The following is a description of a gene set: An abnormality of the viscera of the abdomen. Human Gene Set: HP_ABNORMALITY_OF_THE_ABDOMINAL_ORGANS Abnormality of the abdominal organs species: Homo sapiens, and this is the list of marker genes: FTH1, CCDC40, RFT1, HBA2, GBA1, KIF23, GYPC, CEP164, DNAAF1, CFAP74, DIS3L2, DNAAF6, ALDOB, PNP, KRIT1, HGSNAT, STOX1 (storkhead box 1), THPO, AGA, CD3E, RFX5, SLC16A1, SCO1, AGGF1, CBL (NCBI Gene Id 867), NUP133, CCDC28B, EOGT, ATP11C, PPOX, ATP6AP1, IL12A, NPHP3, NKX2-1, IFIH1, TRPV6, VPS4A (NCBI Gene Id 27183), MITF, CSPP1, PPP2R3C, DNAI2, USB1, ERCC1, RERE, FANCF, PMS2, UFD1, TWNK, ACVRL1 (NCBI Gene Id 94), MOGS, SLC44A1, MEG3, CYP2R1, PHKG2, RRM2B, ADAR, SKIC3 (SKI3 subunit of superkiller complex), PKD1L1, ATP6AP2, SRP54 (NCBI Gene Id 6729), SUMF1, SLC10A1, SDHC, RASGRP1, HADHB, SLC39A7, RFC2, BCL2, DUOX2, GLB1, SMAD2, MMP21, GDF2, BICC1, NME5, SLC26A9, ARPC5, TPI1, CD55, TCTN3, TMEM107, TCF3 (NCBI Gene Id 6929), MT-ND1, PTPN3, GNMT, CDKN2B, POU2AF1, BBS1, SEC63, PUS7, GAPVD1, ABCC8, CFAP300 (NCBI Gene Id 85016), FECH, CEACAM6, GNPTAB, NAB2, PEX19, FANCL, DVL1, GTF2IRD1, MUC5B, TELO2, FAT4, TNFRSF1A, MEFV, ITPR1, CLCA4, SPIB, INS, PSMB8, GCK, AKR1D1, FLNB, SPRTN (NCBI Gene Id 83932), MYRF, FUCA1, CEP83, DLD, FH (NCBI Gene Id 83748), PRKCD, LPL, MNX1, NUP37, MTX2, NTHL1, DNAAF11, PCK1, STX5, CPA1, RHCE, PIK3CG, GPR101, CD79B, INPP5E, PTPRO, XPR1, IGHM, IRF4, FGG, MYCN, PCSK9, EPOR, RAB27A, KCNN4, HBA1, PAX2, CFB, RINT1, CFAP53, MCM4, TFAM, HNF1A, MCM10, CPT2, PEX14, ADAMTS3, SCO2, SEC24C, VPS11, SLC25A4, SLC26A4 (solute carrier family 26 member 4), ACAD9, CHEK2, SDHB (succinate dehydrogenase complex iron sulfur subunit B), TMEM270, TSHR, RAB23, PRSS1, MT-TK, BAZ1B, MVK, SLC6A14, DEF6, GUSB, HLA-DRB1, BBS4, POT1, HESX1, MRPL3, MAGT1, NOTCH1, EWSR1, DYNC2I1, BBIP1, PEX11B, KMT2D, PIGM, FLNC, LARS1, WNT7B, UQCRFS1, AGPAT2, LYZ, MT-TH, CENPF, DLK1, TUFM, LUZP1, DNAH1, FLT1, PCCB, TRIM37, NPC1, LIG4, FOS, GP1BB, SCYL1, PIBF1, RFX6, PDGFB, EPCAM, ABCD3, STAT1, OTC, GNS, TNFRSF11A, NSD1, TBL2, IGKC, PTF1A, SLC5A5, ACD, IL2RB, ABL1, MMACHC, PEX6, HEXB, MPIG6B, GATA2, RFXANK, RAD50, JAG1, MT-ATP6, HSPG2, NCF1, MTR (NCBI Gene Id 4548), IFNG, TULP3, VPS13A, UCP2, IRAK4, SYK, CPT1A, MYBPC3, IFNGR1, SLC39A4, CARD11, LRRC8A, SH2B3, PRKCZ, CD2AP, CAV1, FANCG, ATP5MK, IFT74, DNAAF2, TRAC, NDUFAF4, ATP7A, UROS, TNFRSF9, NAF1, CCDC47, IL21R, ABCC6, COX5A, KMT2B, SCNN1A (NCBI Gene Id 6337), IL7R, WDPCP, LMNA, INSR, ITK, NAE1, TPO, SAMHD1, CD96 (CD96 molecule), FMO3, LIPE, LZTFL1, WDR35, LDLR, NCKAP1L, PLEC, LHX3, DCDC2, GALM, COX14 (cytochrome c oxidase assembly factor COX14), ELANE, HMGCL, MT-TS2, PIK3R1, SMARCAL1, MT-CO3, CD70, KIF3B, SCNN1B, KCNQ1, PPARG, ARX, CFAP221, ADA2, DYNC2H1, OTUD5, TP53, MIF, DDOST, TRAF3IP1, ODAD4, LAT, ATP7B, IER3IP1, RTL1, TINF2, ACBD6, BTNL2, ALAS2, NBEAL2, COG1, SLC25A1, IFT172, SH2D1A, AP3B1, RHD (NCBI Gene Id 6007), GUCY2D, IL36RN, APOC2, AKT1, HMOX1, FTL, TALDO1 (transaldolase 1), HMBS, SCAPER, NBAS, ANLN, NME8, DHCR24, BARD1, FANCM, STXBP2, HOXD13, IKBKG, VPS45, G6PC3, FOXJ1 (forkhead box J1), ADAMTS13, ZFTA, PRKCSH, MECP2, CSF3R, NPHS2, IFT140, NDUFS4, C4A, IL17F, ACTN4, CA2, LRBA, GTF2IRD2, RMND1, POLE, CDKN1C, TWIST1, SMAD4, ITCH, SERPINA1, UBR1, BCR, NSD2, DNASE2, SMARCE1, SOCS1, GANAB, CD19, CLIP2, PIK3CA, STK36, ALG9, ATM, SKIC2, SLC34A2, HBB, PEX12, POU6F2, RNASEH2C, HADH, UBE4B, DNAJB13, NUP205, AIP, AP1S1, PALLD, INPPL1, CLPB, ARSA, SPAG1, KRAS, MCTS1, TTC8, LSM11, CTRC, ATRX, LYRM4, RAG1, CCND1 (NCBI Gene Id 893), BPGM, IRF5, ALDOA, TRMT5, SLC19A1, TNFRSF13C, BLK, CD27, GCGR, PTEN, HSD17B4, MAPK8IP3, RAD51C, TMEM70, RAD51, GPC4, TLR8, TFE3, SMPD1, CAVIN1, BCL11A, IRF2BP2, FOXF1, CFAP410, ALG1, MT-TQ, SAA1, MT-ND3, ABCG5, HSD3B7, RPSA, SPEF2, HCK, RMRP, GNB2, TIMMDC1, SLC51B, TCF4, ARHGDIA, ABCC2, AXIN1, PKD2, ABCB11, NDUFS8, B4GALT1, GPIHBP1, AFF4, SIK3, TRIP13, VPS37D, ATP5F1D, PAX8, SFTPA2, PGM1, RSPH1, AIRE, ANKS6, UBAC2, DNAH5, KDM6A, MT-ND4, CFC1, BRAF, STX11, PNPLA2, CCNO, CASK, FOCAD, CD79A, KYNU (kynureninase), FANCI, SPIN4, NCF4, SPOP, LTBP3, SAR1B, PRSS2, PCCA, KRT18, DNAAF5, NODAL, NUP107, SLC7A7, USP9X, APPL1, CDK4, CTCF, APOB, NFKBIA, PMM2 (NCBI Gene Id 5373), TERF2IP, SLC20A2, TF, ETFB, PRIM1, CPLX1, TPP2, CYP7A1, PYGL, DNAJC19, RECQL4, SCN4A, CFAP298 (NCBI Gene Id 89757), PDGFRL, SMARCD1, NPHS1, BAP1, NDUFA6, CASR, TRHR (thyrotropin releasing hormone receptor), ARVCF, PTPN2, RSPH4A, FANCD2, FDX2, MRE11, CTNNB1, FCGR2A, CDIN1, B9D2, PEPD, MT-TL1, EXTL3, FAM111A, CDKN2C, CEL, ORAI1, VPS33B, SCARB2 (NCBI Gene Id 950), FASLG, FYB1 (NCBI Gene Id 55458), NDUFS6, SHARPIN (SHANK associated RH domain interactor), AHDC1, CCDC39, ADAMTSL2, TRAPPC11, RPGR, SKI, ERCC8, ACOX1, HTRA2, BBS2, MRAS, ZNF699, FAM111B, KLF11, NDUFS7, NDUFV1, IL1RN (interleukin 1 receptor antagonist), DNAH11, TNPO3, IFT80, MT-TN, CDC73, DMPK, NR1H4, ZEB2, ARL6, PCSK1, ARID2, YME1L1, PIK3CD, POU1F1, ARG1, RAF1, ALG13, GALT, AAGAB, TYMP, UQCRH, UNC13D, COX4I2, STAT4, GTF2I, ACVR1B, LRPPRC, MAD2L2, FADD, HNF1B, GBE1, MT-CO1, ATP8B1 (NCBI Gene Id 5205), KATNB1, RNASEH2A, CDON, NDUFA11, SOX10, KIF12, MST1, GALNS, C2orf69, STN1, MYO5B, COX15, HLA-DPA1, AGL, TNFRSF1B, HPGD, MT-CYB, EDNRA, KIT, RRAS2, CORIN, SCLT1, NDUFV2, UNC45A, APOL1, RRAS, COQ8B, ACADVL, BACH2, JAM3, MAN2B1, SPINK1, PKHD1, TSC1, SLCO2A1, EP300, ARHGAP24 (NCBI Gene Id 83478), PRPS1, GALE (NCBI Gene Id 2582), MFN2 (NCBI Gene Id 9927), BTK, CLXN, MT-TV, FOXN1, MPL, VPS33A, MT-TW, PNPLA6, HBG1, HK1, LBR, TRAF3IP2, PEX3, DSE (dermatan sulfate epimerase), CNTNAP2, ESCO2, TSC2, GCDH, POLG2, XIAP, F10, FOXRED1, PDE11A, RARB, SOX4, NLRP3, CYP27B1, BRCA2, DYNC2LI1, FBXL4, FOXP3, EFL1, HNF4A, LIPA, PKLR, FCHO1, ACP5, RBCK1, PIGA, CEP19, TBC1D8B, RNASEH2B, LIG3, SPTA1, LRRC56, NKX2-5, TRIM28, DNAL1, IL17RC, BCS1L, FARSA, NDUFA2, NDUFB9 (NADH:ubiquinone oxidoreductase subunit B9), CFTR, CBS, PLAGL1, GATA6, COG4, GNE, DHCR7, CCDC32, ABCA12, MT-ND2, KCNQ1OT1, TFR2, NPHP4 (NCBI Gene Id 261734), ALG2, LAMA5, CTSK, STAT6, FGFR2, CCDC115, VHL, AP3D1, ACADM, ACVR2B, CYP27A1, FGFRL1, IVD, MED25 (mediator complex subunit 25), PHYH, STIM1, IFT43, YARS2, XPNPEP3, SERPINE1, CYBB, MTTP, BCKDHA, NDUFB10, TKFC, MS4A1, SBDS, RBM8A (RNA binding motif protein 8A), BCAP31, BLNK, LDLRAP1, PIGG, LONP1, KMT2E, BUD23, LRP5 (NCBI Gene Id 8058), NFKB2 (NCBI Gene Id 4791), LYN, TCN2, AP1B1, CRB2, DUOXA2, SLX4, SDHA, ANTXR1, ROS1, ELP1, PDX1, FANCB, TBX1, GATA1, PEX26, ZIC3, NAA10, BRCA1, JMJD1C, TSHB, NOTCH2, LTBP4, IDS, LYST, CISD2, ANKFY1, NHP2, CD40LG, IRF8, RASA2, SOS2, ALG5, STUB1, LHX1, MSH6, CC2D2A, ATAD3A, BMP6, PRF1, DAAM2, SNX14, IL2RA, DNAJB11, STEAP3, MPI, RFWD3, COG8, VIPAS39, ICOS, BBS12, FCGR3B, NEUROG3, MPC1, NSMCE2, KLRC4 (killer cell lectin like receptor C4), IL6ST, DCTN4, TRPC6 (NCBI Gene Id 7225), TG (thyroglobulin), FANCC, GIMAP5, TMEM126B, B9D1, ANKRD55, MT-TF, HAMP, TOGARAM1, ACSL5, AMACR, BBS10 (NCBI Gene Id 79738), NPC2, SLC11A2, SHPK, TCIRG1, FARSB, EARS2, PDGFRA, RREB1, SLC4A1, HYLS1, CCBE1, SC5D, YARS1, SMARCB1, PRDM16, PCYT1A, PSMB10, CEACAM3, NAGLU, LPIN2, NDUFAF2, TBXAS1 (thromboxane A synthase 1), MT-ATP8, CDKN1A, MRPL39, PTRH2, MCCC1, VPS50 (VPS50 subunit of EARP/GARPII complex), HMGCS2, STX1A, TCTN2, HAVCR2, IL17RA, MYORG, B3GLCT, AHCY, ANK1, RSPH9, SLC17A5, TCTN1, AP2S1 (adaptor related protein complex 2 subunit sigma 1), TYMS, GH1, MECOM, PUF60 (NCBI Gene Id 22827), HNRNPA1, H19, DPAGT1, MAP2K1, CNOT1, GAS2L2, MED12, HBG2, OCLN (occludin), GLUD1, SLC37A4, GSTM3, XYLT1 (xylosyltransferase 1), CDAN1, CYBC1, C1S (NCBI Gene Id 716), MEGF8, CYP7B1 (NCBI Gene Id 9420), REL, TBX5, ERBB3, LCAT, MYD88, RUNX1, TGFBR2, BRD4, PDCD1, GCLC, C4B, COX10, MT-ND5, ARID1B, PEX10, NEK10, ERCC4, MMEL1, COA8, PHEX, TMEM237, INVS, MSH2, ZAP70, SAMD9L, ODAD3, ACADS, RABL3, SDCCAG8, SMARCC2, KDM1A, G6PC1, EXOC2, EMP2, CLEC7A, ASS1, MYH11, CHD6, PRTN3, SGSH (N-sulfoglucosamine sulfohydrolase), CPOX, PEX7, PALB2, ODAD2, BBS9, SASH3, KIF20A, NAGA, KDM5C, ACTG2, ALPK1, SUCLG1, NUTM1, PCK2, FGB, SLC2A2, CASP8, LMBRD1, ASXL1, MKKS, NGLY1, TRIM32, OAS1, NDUFAF5, SLC2A1, NOD2, SON, CTBP1, CHST14, PC, GEMIN4, RHAG, XRCC2, CLCN7, NDUFAF3, FOXE1, SERPINC1, FLI1, WDR19, RSPH3 (NCBI Gene Id 83861), NDUFB11, NAGS, JAK1, IL2RG, NDUFS1, FANCA, SNX10, FKBP6, MCIDAS, HGD, PEX2, GFM1, INF2, BLVRA, POLR3A, SURF1, IGLL1, SPRED2, NBN (NCBI Gene Id 4683), PSMB4, SEC23B, PEX1, SEMA7A (NCBI Gene Id 8482), MYC, PHKB, WDR1, DAW1, DZIP1L, PARN, MICU1, DKC1, MT-ND6, EPB42, ADRA2A, MMAB, CIDEC, CARS2, CIROP, YY1, RBPJ, PI4KA, MET, HIRA, CRELD1, UMPS, ARL13B, SOX11, SLC25A19, HEPACAM, FARS2, NELFA, CTC1, KIAA0753, HMGA2, CTLA4, TERC, SLC29A3, ELN, IRF1, PLCE1, RAD51D, INTU, MC1R, HFE, MDM2, APC2, NUP160, G6PD, PIGS, PIGL, MNS1, PIK3C2A, ABHD5, DOCK11, EPB41, NADK2, UQCRB, SEMA4A, SLC25A20, SPTBN1, ARID1A, DOCK2, PFKM, PEX16, MMAA, VCP, NUBPL, RPS20, DNAI1, SP110, FAH, SPTB, CP, ALMS1, CA5A, MT-CO2, RNF31, RAC2, ZFX, HLA-B, SLC22A5, CREBBP, ODAD1, BMPR1A, XK, UROD, PLIN1, TBX19, MUTYH, GK, PKD1, TMEM199, TNFSF15, LHX4, SOS1, FGA, DPM2, RTEL1, WRAP53, NOP10, IGF2, IL6, AUH, NDUFAF1, WFS1, RFXAP (NCBI Gene Id 5994), HYDIN, ETFA, NCF2, CASP10, SLCO1B1, DYNC2I2, ACAT1, CFAP52, ADK, METTL27, COL14A1, SCNN1G (sodium channel epithelial 1 subunit gamma), ATP5F1A, GPD1, IQCB1, RAG2, KCNH1, ALG8, NLRP12, CDC45, APOA1, ESAM, KCNAB2, PROP1 (NCBI Gene Id 5626), NRAS, NDE1 (NCBI Gene Id 95348), CEP120, SLC16A2, CTSA, IFT122, NDUFS2, TGFB1, DOCK6, B2M, KLF1, TTC7A, TET2, NDUFAF8, CLDN1, GABRD, NDUFA1, CYP19A1, PPP1R21, TNNI3, IL12RB1, MEN1, RELN, IGF2R, RORC, NLRP1, MRPL44, IL18BP, ZMYM3 (NCBI Gene Id 9203), GP1BA, C1QBP, PTPRC, TNFRSF4, COMT (NCBI Gene Id 1312), CHD7, SLC9A3, CD3D, SLC30A10, PSAP, IGHG2, CDKN2A, NPHP1, COG7, SLC25A13, LACC1, DNAH9 (NCBI Gene Id 8709), MTRR, DNAAF3, ERAP1, ZPR1 (ZPR1 zinc finger), SLC35C1, NUP93, RIT1, NEUROD1, DRC1, OSTM1, SLC39A8, CFAP45, GPC3, NDUFB3, CR2, PHKA2, ABCB4, HYMAI, MADD, SDHD, STK11, CTNS, NPM1, MYPN, FBP1, SLC11A1, GPI, PIEZO1, KCNJ11, ERCC6, PSTPIP1, PTPN22 (protein tyrosine phosphatase non-receptor type 22), ADA, TKT, SETBP1, ARMC5, CTSC, POMC, TERT, XRCC4, LEMD3, HADHA, ENPP1, PSMG2, IL23R, NOTCH3, DHFR, DHDDS, ABCD1, NUP85, BMPER, ABCA1, RNU4ATAC (RNA, U4atac small nuclear), ASAH1, COG5, BRIP1, ZMYND10, TARS2, FERMT3, RPGRIP1, DPM1, TTC21B, AGR2, TREX1, IKZF1 (NCBI Gene Id 55429), ATP5F1E, CD247, MAFA, IFT56, TRMU, APC, MAGI2, ARSB, MYO1E, IKZF3, TNFRSF13B, DDRGK1, PDGFRB, GNAS, KPTN, MRPS28, HYOU1, IL10, TLR4, RNF43, TMEM94, ZNFX1, PAX4, CEP290, CDKN1B, IFT27, SLC38A3, CFAP418, FBN1, PTPN11, IYD, RPGRIP1L (NCBI Gene Id 23322), ABCG8, GLIS3, CALR, UBE2T, ASL, SPI1, APOE, TMEM231, GNA11, MGMT, FAS, NDUFS3, PSMB9, USP18, BBS7, F5, COL4A3, CASZ1, GAA, TSFM, LETM1, SMARCA4, SF3B1 (splicing factor 3b subunit 1), DCLRE1C, BOLA3, SLC25A15, PLEKHM1, POLG, LIMK1, BBS5 (Bardet-Biedl syndrome 5), DNAJC21, ALDH1A2, RIPK1, DOCK8, DLL4, HNRNPA2B1, NEK1, BTD, GDF1, HJV, MARS1, BCHE, WT1, PRDX1 (NCBI Gene Id 5052), NHLRC2, NFKB1, POLD3, CD28, ENG, IARS1, ARHGAP31, JAK2, BSCL2, MYL2, ETFDH, SRSF2, NEU1, BMP2 (bone morphogenetic protein 2), PMS1, ALG6, LMNB2, DNAJC30, FANCE, ATPAF2, GPR35, SLCO1B3, SEMA4D, TTC12, TMEM165, HLA-DPB1, CLCNKB, MICOS13, LMF1, PEX13, ATP6V1B2, MLXIPL, WNT3, NFS1 (NCBI Gene Id 96810), GLRX5, NEK8, UGT1A1, DPF2, JAM2, GALK1, GSN, REST, LZTR1, USP53, TXNDC15, PERCC1, DGUOK, EIF4H, MRPS7, CIITA, TMEM67, SPEN, STAT3, MMUT, MPV17, PEX5, SLC51A, BCL6, PLAAT3, AKT2, IL12A-AS1, EIF2AK3, DNAAF4, SFTPC, PRKAR1A, STRA6 (NCBI Gene Id 64220), JAK3, PARS2 (NCBI Gene Id 91517), TMEM216, SLC40A1, HSD17B10, RNU7-1, SUPT16H, BLM, TNFSF12, MMP23B, PDPN, ZFYVE19, TRNT1, DNASE1L3, MT-TE (NCBI Gene Id 4556), SAMD9, OFD1, CCR1, IDUA, MLH1, NLRC4, MKS1, POLD1, CD81, TOMM7, TNFSF11, COG6, TJP2, TNNT2, BAAT, RHBDF2, KCNN3, CYBA, SLC12A3